The following is a description of a gene set: The chemical reactions and pathways involving carbohydrates, any of a group of organic compounds based of the general formula Cx(H2O)y. studied in species Mus musculus Mouse Gene Set: GOBP_CARBOHYDRATE_METABOLIC_PROCESS, and this is the list of marker genes: Sec1, Gale, Atp1a3, Parp1, Gpd1l, Man1a2 (NCBI Gene Id 99756), Usf1, Grb10, Mup3, Scarb2, Pfkl, Spam1, Slc25a12, Lipa, B4galt5, Mgat2, Gsto1, P2ry6, Adra1b, Gusb, Pou1f1, Gdf2, St6galnac1, Pgls, Gla, Usp7, Pgm5, App, Gys2, Adcyap1r1, Pfkfb1, Pmm1, Eif6, Pdk3, Chid1, Ogt (O-linked N-acetylglucosamine (GlcNAc) transferase (UDP-N-acetylglucosamine:polypeptide-N-acetylglucosaminyl transferase)), Aldob, Npy1r, Tgfb1, Tnf, Nfe2l1, Hdac4, Lancl3, Glb1l2, Stbd1, Slc25a10, Hnf4a, Kat2b, Irs1, Adipor1, Man1a, Tigar, Epm2aip1, Fbp1, Chst12, Ins1, Myorg, Pygb, Nr1d1, G6pdx, Chst7, P2ry1, Pgm2l1, Jmjd8, B3galt2, Gper1, Mtch2, Pth1r, Trim63, Inppl1, Igf1, Chst11, Bcl2l13, Aldoart1, Idua, Mup5, Blvra, Atf4, Gaa, Kcnj11, Eno3, Fabp5, Hk1, Hyal1 (hyaluronoglucosaminidase 1), Dyrk2, Atf3, Mlx, Hyal5, Snord32a, Ddit4, Gyg1, Prkag1, Slc25a13, Ppargc1a, Brat1, Ncoa2, St8sia5, Wdr45b, Ifng, Dcxr, Edem2, Chst9, Parg, Akt2, B3gat3, Ovgp1, Nln, Gsto2, Zbtb7a, Mup11, Pgd (NCBI Gene Id 97145), Ugp2, Pgam1, Pgf, Man2b1, Ogdh, Slc3a2, Treh, Prkag2, Insr, Atg12, Fut2, Nr3c1, Adcy10, Gnptg, Gk, Gulo, Fut4, Ppp1r1a, Chit1, Chst2, Hif1a, Foxo1, Rpia, Pck2, Chst1, Pdgfb, Pask, St8sia3, Man2b2, Actn3, Nagk, Inpp5k, Ptger4, Gapdh, Edem1, Pik3ca, Pgghg, Myc, Kcnq1, Lancl2, Gk5, St3gal4, Pgam2, Idh1 (isocitrate dehydrogenase 1 (NADP+), soluble), Taldo1, Nr1h4, Stk40, Gpd2 (NCBI Gene Id 99372), Casd1, G6pd2, Renbp, Siae, Ncor1, Pfkp, Fut9, Gmppb, Rgn, Tfap2b (NCBI Gene Id 98405), Akt1, Gdpgp1 (GDP-D-glucose phosphorylase 1), Ugt1a6a, Glb1l, Ap2a1, Hyal4 (NCBI Gene Id 77042), Wipi2 (WD repeat domain, phosphoinositide interacting 2, NCBI Gene Id 76581), Enpp1, Hkdc1, Ins2, Tkfc, Prkn, Slc3a1, Akr1b1, Myof, Lhcgr, Pck1, Lrp5, Slc39a14, Dgkq, Shpk, Cpt1a, Pfkfb3, Ganab, Phkg1, Snord35a, Otog, Bola3, Oas1f, Dhtkd1, Clk2, Phka2, Rubcnl (NCBI Gene Id 380917), Hectd4, Man2a1, Ppp1r3a, Pofut1, Myh9, Gk2 (NCBI Gene Id 14626), Has1, Ppp1r3c, Plek, B4galt4, B4galt7, Pomk, Gsk3a, Amy2a5, Gnmt, Has2 (hyaluronan synthase 2), Spata20, Pomc, Aldoa, Pgk2, Ptpn2, Dlat, Nupr1, Nfkb1, Galnt3, Il6, Hmgb1, Gckr, St6gal2, Gys1, Fcsk, Dera, Fbp2, Tcf7l2, Flcn, Angptl3, Gnb3, B3glct, Pdha1, Mup1, Glyctk, Chil4, Pkm, Mogat2, Hk3, Eno2, Car5a, Mlst8, G6pc2, Xylb, Rpe, Pdk2, Nkx1-1, Ppp4r3b, Pygm, St8sia6, Psen1, Edem3, Chst4, C1qtnf2, 1810024B03Rik, Serpina12, Ldha, Cd244a, C1qtnf12, Ntsr1, B3gat2, Snord34 (NCBI Gene Id 27210), Bpgm, Ppp1ca (NCBI Gene Id 19045), Gapdhrt, G6pc1, Has3, Mlycd, Galk1, Oas1e, Ier3, St6galnac3, Neu1, Npc1, Mas1, Prxl2c, Htr2a, Prkaca, Galk2, Gpi1, Pla2g4a, Gpt2, Galt, Rbks, Pofut2, Man2a2, Pdk1, Ppp1cc, Nans, Sirt6, Neu4, Chst3, Sis, Pdx1, Gm2a, St8sia2, Chi3l1, Ctbs, Acacb, Fuom, Dysf, Zmpste24, Prkaa1 (protein kinase, AMP-activated, alpha 1 catalytic subunit), Tff3, Gykl1, Ydjc, Cyp2j6, Chst10, Pfkm, Angptl8, Pth, Apod, Mgam, Otogl, Pklr (pyruvate kinase liver and red blood cell), Abo, Erfe, Ppp1r3b, Aldh1a1, Gapdhs, Neu2, Zbtb20, Hexb, Rora, Kat2a, Ranbp2, Coq3, Phkg2, Oma1, Mfsd8, Gcg, Epm2a, Per2 (NCBI Gene Id 18627), Phka1, Dhdh, Fggy, Trp53 (transformation related protein 53), Hsd11b1, Sesn2, Wdr45, Ppp4r3a, Prkag3, Aldh1a7, Fuca1, Mup4, Got1, Lct, Fuca2, Nhlrc1, Glt6d1, Csl, Ero1a, Igf2, Hyal3, P2rx7, Chst5, Ppp1r3e, Chst15, Man2c1, Hk2, Dgat2, Ext1, Mogs, Hexa (NCBI Gene Id 15211), Rbp4, Oas1h, Pgm2, Pdk4, Gnptab, H6pd, Serp1, Adora2b, Stk11, Gnpda2, G6pc3, Chst8, Ptges3, B4galt6, Sirt7 (sirtuin 7), Prkaa2, Mup2, Atp1a2, Mir423, Wdtc1, Slc4a1, 4930568D16Rik, Gclc, Arnt, Git1, Wipi1, Bckdk, Adipoq, Arl2, Amy1, Mtor, Arpp19, Il6st, Nudt5, Foxk2, Glb1l3, St3gal2, Mpdu1, Nisch, Mogat1, Src, Stat3, B3gat1, Sik2, Lep, Cltc, Pdha2, B3galnt1, Pcdh12, Cry1, Manba, Fbn1, Eno4, Man1c1, Ppp1r3f, B4galt1 (UDP-Gal:betaGlcNAc beta 1,4- galactosyltransferase, polypeptide 1), Gcgr, Aldoc, Ext2, Bad, Myog, Sds, Lcmt1, Klb, Akr1a1, Adrb1, Trex1, Zfp692, Ucp2, Pfkfb2, Ep300, Agl, Snord33, Ggta1, Atg2a, Slc4a4 (solute carrier family 4 (anion exchanger), member 4), Nnmt, Ndst1, St8sia4, Smpd3, Sorbs1, Idh2, Slc2a6, Kbtbd2 (kelch repeat and BTB (POZ) domain containing 2), Gnpda1, Wdr5, Uchl1, Oprm1, Cbr2, Fam3a, Kl, Man1b1, Comt, Igfbp3, Chia1, Fgl1, Gpt, Gfpt1, Atg3, Gm1110, Lepr, Amy2a1, Fut1, Hyal2, Pygl, Mlxipl, Gapdhrt2, Mtcl2, Plcd1, St6galnac4, Fkrp, Gba2, Pgk1, Foxk1, Lalba, Prkg1, Lancl1, St6galnac5, Cbfa2t3, Slc23a2, Igfbp4, Tpi1, Ddb1, Il3, Slc45a3, Slc35b4, Atg2b, Egf, Avpr1b, Cs, Sirt1, Snca, Ptafr, Pmm2, Lctl, Naga, Xpc, A3galt2, Mdh2, Ppp1r3g, Chil3, Crtc2, Gsk3b, St6galnac6, Eno1, Oas1d, Col6a1, Neu3, Coq2, Oas1a, Fpgt, Esrrb, Ganc, Adpgk, Midn, Pgp, Gpld1, C1qtnf3, Ppp2ca, C1qtnf1, Gbe1, Onecut1, St8sia1 (NCBI Gene Id 320852), Rb1cc1, Sord, Mst1, Oas1b, Slc2a8, Cox11 (cytochrome c oxidase assembly protein 11, copper chaperone), Phlda2, Rptor, B4galt2, Mir143, Slc25a11, Selenon, Ppp1r2, B4galt3, Pdhb, Mapk14, Gne (glucosamine (UDP-N-acetyl)-2-epimerase/N-acetylmannosamine kinase), Oas1g, Khk, Pgm1 (phosphoglucomutase 1), Obp2a, Errfi1, B3galt1, Gpd1, Gabarapl1, Hexd, Acadm, Uxs1, Chst14, Pcx, Gbgt1, Eno1b, Slc37a4, Ppara, Mpi, Ppp1cb, Irs2, Galm, Clstn3, Rorc, Pfkfb4, Supt20, Mdh1, Gck, Pgm3, Glb1, Pmaip1, Phkb, Ppp1r3d, Sik1, Pik3r1, Oas1c, Aldoart2